Given this list of marker genes MT-TL1, CEP85L, ABAT, GTF2IRD2, LIMK1, SLC5A5, AIP, CEACAM3, SLC6A14, PDHA1, TSR2, BNC2, BBS1, TBX1, LHX3, MMAB, SLC25A4, RPL31, SERPINA1, USP48, PANK2, MEN1, ANXA11, RYR1, ATM, ZIC2, RPS26, ATXN8OS, GP1BB, DPYS, UBE2L3, DCX, FLT4, CHMP2B, HADHA, MAPT (microtubule associated protein tau), PON1, GSTM3, CASR, TWNK, MT-ND5 (mitochondrially encoded NADH:ubiquinone oxidoreductase core subunit 5), IYD, SEMA4A, VPS35 (NCBI Gene Id 91808), NUBPL, TLR7, NHLH2, POLD1, KCNT1, TRHR, NFU1, DLL1, DNAJC30, FGF17, UCP2, SIK1, DMXL2, ATP9A, RELN, DNAJC13, MT-TN, OPTN (optineurin), RPS27, PPT1, TNFAIP3 (TNF alpha induced protein 3), BANK1 (NCBI Gene Id 55024), MT-ATP8, MOG (NCBI Gene Id 4340), GNRH1, CDKL5, ASL, CPT2, BBS4, GSN, GPR101, MSH2, MTRR, MCCC2, NODAL, PINK1, MTR, CPOX, SIX3, BMP6, TPO, PDCD1, HADH, HMGCL, MMP1, MT-TH, FXN, ATXN1, TGIF1, USH1C, TGFBR2, PBX1, TP53, BCKDHB, KMT2B, RPS29, SLC19A2, MECP2, NR3C1, ENSG00000288330 (ataxin 8), HTR2A, DAOA, NHLRC1, PNKP, CTSF, MT-TQ, ESPN, PLCH1 (phospholipase C eta 1), MSTO1, KDM1A (NCBI Gene Id 23028), NCF1, MATR3, NDUFA1, SMPD1, STAG2, HIBCH, GALT, LYRM7, BTD, CHEK2, NDUFB11, TAMM41, PON2, SLC19A3, PTRHD1, COX5A, ATXN3, PROK2, GK, TRANK1, BUD23, IFT172, NAA10, COQ2, RPS7, ANG, DRD3, FA2H, FKBP6, DDC, AFG3L2, TREM2, TK2, VPS13C, TIMMDC1, COL7A1, HTT, TAC3, CLCA4, GM2A, GNA11, SCN2A, RPS17, GIGYF2, CLN6, EDNRA, PLA2G6, PRKACA, MT-TT, GABRA1, SRPX2, PROKR2, DRD2, ZFX, CR2, SDHA, PRKCG, FOXE1, ACADM, AARS2, DNA2, MKS1, BCR, BBS10, ATP2A2, EPM2A, SLC7A6OS, CASK, CBS, PON3, USH1G, IVD, SHH, NAXD, ARMC5, ACADSB, PDZD7, ADH1C, JMJD1C, HTRA2, P2RY11, HLA-DQA1, ATP13A2, PSAP, SLC31A1, APOL2, CP, RPL8, NDUFS7, ATP1A3, IGHG1, PTCH1, FOXH1, WARS2, CDKN1B, RPL27, MAN2B1, SLC9A3, SCAPER, CIB2, FGF14, IDUA, KIAA0319L, EHMT1, TLR3, DCTN1, PLP1, LHX4 (LIM homeobox 4), ATP8B1, PPARGC1A, PRDX1, CACNA1A, GRIN1, FCGR2B, KISS1R, MEFV, ATRX, PXK, NKX2-5, JPH3, WDPCP, IRF5 (interferon regulatory factor 5), SPP1, GYS2, NDUFA11, DCTN4, TMEM106B, GLI2 (GLI family zinc finger 2), RPS6KA3, PIGA, ACADVL, MT-CO1, RPL18, NDUFB3, AGR2, HMBS, ZNF365, TG, ATXN2, TSFM, NDUFV1, TBK1, NDUFA6, CHRNA4, RPL26, NDUFAF5, FGFR1, LGI1, PER2, ABCC8, RPS10, NDUFB10, GUF1, USP8, CYP24A1, RPS28, KRAS, DAO, NAA60, TBL2, MMAA, MT-TS2, YARS2, RPL35A, NBAS (NCBI Gene Id 51594, NBAS subunit of NRZ tethering complex), VPS13A, UQCRC1, C9orf72, SLC11A1, CTLA4, BBS2, ARX, XK, GAS1 (NCBI Gene Id 2619), FMR1 (fragile X messenger ribonucleoprotein 1), FGF8, MPV17, MMADHC, SLC25A20, RPL35, CISD2, BRCA2, ARSG, RMND1, TTC8, ATP5F1E, BOLA3, FIG4, DUSP6, PFN1, MT-ND1, MT-CYB, MT-ND6, AOPEP, RRM2B, USH2A, KCNJ11, CUX2, SLC32A1, FOXRED1, ABCB4, CACNA1I, SLC2A3, ABCA7, SLC25A13, RTN4R, IRAK1, SPR, HEXA, PTPA, STUB1, VPS37D, NKX2-1, DLD, CACNA1H, C19orf12, SIM1, MAPK10, TET3, NDUFAF3, UFD1, RPS19, BBS7, ELN, KRT18 (keratin 18), HIRA (histone cell cycle regulator), TNFSF4, EPCAM, RPL5, TGFB1, AMACR, TNIP1, MAPK1, NDUFS2, AVP, PRNP, NDUFS1, GLA, SYN2, CFAP418, GLE1, CLCN4, PCCB, KCNJ2 (NCBI Gene Id 3759), NDUFAF8, BCS1L, PSEN1, KCTD17, RPS24, THOC2, GABRB2, DNASE1, RPL9, GCH1, ABCB11, TCN2, STIL, NSMF, PER3, POLG2, CEP78, SLC39A4, HNF4A, TAF15, ALDOB, DNM1 (dynamin 1), CHD8, GPR35, CRH, CDH23, TMEM240, KCNA1, P4HA2, RREB1, ADGRV1, CEACAM6, ARSA, ASS1, SCLT1, APOE, MST1, ABCD4, TH, ACAT1, BBS5, SPTBN1, EIF4G1, CACNA1G, PIK3CA, IFT74, HJV, LMBRD1, MKKS, GRN, SCN1A, TOR1A, TACR3, FCGR3B, CFTR, ASPA, BLK, CTSH, DUOXA2 (dual oxidase maturation factor 2), CSF1R, NDUFS3, SLC6A4, MMUT, DNAJC5, SCARB2, CHCHD2, NDUFB9, CHD7, NEUROD2, TCF4, SQSTM1, NDUFS4, TSC1, OTC, PCDH15, ARL6, SCN1B, SLC7A7, SNCA, GTF2I, GRM7, HLA-DQB1, BMPR1A, CEP19, PMS1, MCCC1, YY1, PRKAR1B, SGCE, CHRNB2, DNMT1, NFS1, NDUFV2, ATPAF2, CABP4, IFT27, NDUFAF4, TSPOAP1, CPS1, CARS1, BAZ1B, UCHL1, GRIN2A, MSH6, MRPL39 (mitochondrial ribosomal protein L39), STX16, SUGCT, CHD2, GNRHR, SEMA4D, MAMLD1, DBT, AR, DNAJC6, STX1A, NEFH, CCNF, HAMP, MT-ND4, PTPN22, MLH1, TMEM270, PMS2, UNC13A, CRKL, DPYD, EIF2B1, ERBB4, WFS1, PRPH, SCO2, AP1G1, RPS20, MT-TW, CLRN1, BCKDHA, PAH, USP18, PROP1, WHRN (NCBI Gene Id 8016), PPP2R2B, NOTCH3, MIF, JAZF1, GDAP2, SPG21, TBP, POLG, NDUFAF2, PAX2, GABRG2, XPR1, HS6ST1, ALAD (aminolevulinate dehydratase), MAGEL2, APOL4, ITGAM, SLC4A1, CDKN2B, ITPR1, CLIP2, GBA1, RPS15A, RPL11, STAT4, WDR11, SOD1, GTF2IRD1, MT-ND3, PODXL, MT-ATP6, GATA1 (NCBI Gene Id 2623), C4B (complement C4B (Chido/Rodgers blood group)), ATXN10, PDGFRB, IFNG, FKBP5, GPRC5B, PARK7, COMT, HLA-DRB1, HNRNPA1, SLC2A1, NDUFS6, GNAO1, MT-ND2, SPRY4, C4A, BBS9, CHRNA2, MMACHC, SPAST, UBQLN2, ACADS, SMARCB1, TTC19, GLT8D1, ETS1, MTHFR, BRAF, NDE1, TMEM126B, SLC25A15, IL10, FBP1, FUS, ATP5MK, MRPS16, HEATR3, RFC2, CTCF, PAX8, GLDC, NR4A2, EIF4H, PSEN2, ARVCF, SLC25A22, HARS1, TRIM32, MT-CO2, MUTYH, CA5A, KCNN4, HMOX1, NR1H4, POLE, GNAS, SEC24C, DEPDC5, ABCB7, VCP, CPT1A, GCLC, ADA2, TPH2, MT-CO3, SMC1A, SNCAIP, FMO3, CDON, RARS2, PCCA, MT-TF, NPHP1, PDGFB, VAPB, GCSH, DGUOK (NCBI Gene Id 1716), CFAP410, ATP7B, COASY, HFE, DUOX2, TSHR, PRKN, PIGQ, HTRA1, ATP5F1A, GABRB3, ATP5F1D, MT-TL2, HNF1A, HLA-B, CEP290, PRKAR1A, SLC52A1, SLC26A4, CHI3L1 (NCBI Gene Id 7836), CDKN1A, KISS1, MYO7A, OCRL, SLC26A9, JRK, IMPDH2, DISP1, CYP27A1, SLC20A2, TARDBP, METTL27, TSC2, NEK1, TBC1D7 (NCBI Gene Id 51256), RPL15, NAGS, TSHB, LZTFL1, PTS, PEX2, SLC25A19, SDCCAG8, HCRT, TFAM, TREX1, SLC22A5, CDKN2C, ALG12, BBIP1, POU1F1, HESX1, GFAP, IRF4, ALDH4A1, HLCS, BBS12, HADHB, CHCHD10, COG8, SLC1A2, CRIPTO, TRIM8, PIGP, AP2S1, NDUFAF1, TDO2, PDE11A, SYNJ1, LRRK2, NDUFS8, here is a description of the gene set: Human Gene Set: HP_ABNORMAL_DIMINISHED_VOLITION Abnormal diminished volition A reduction in willful and motivated goal-directed behavior that is considered the determinant of behavior and adaptation that allows individuals to get started, be energized to perform a sustained and directed action. species: Homo sapiens